Given this list of marker genes TMCO1, PTPN22, KITLG, EDNRB, CHN1, SALL4, EDN3, TFAP2A, SOX10, LMNA, SNAI2, PEPD, MITF, FAS, HRAS, WRN, KIT, TERT, PAX3, TYR, MAFB, here is a description of the gene set: Human Gene Set: HP_PATCHY_HYPOPIGMENTATION_OF_HAIR Reduced pigmentation of hair in patches. Patchy hypopigmentation of hair studied in species Homo sapiens